Given this list of marker genes E030030I06Rik, Zwint, Pitpnm3, Tial1, Postn, Dmtf1l, Ep300, Smim13, Setdb1, Tsc22d2, Amn1, Fmnl2, Cnot6l, Haus6, Zfp36l2, Arid4a, Ppp2ca, Fbxl12, Cp, Eif2b1, G3bp2, Pan3, Cpsf6, Cav2, Nkd2, Plcl2, Slc23a2, Smim10l1, Vtcn1, Mbtd1, Exd2, Ifi47, Nr4a2, Scai, Rab7, Pfn2, Dnal1, Kcnj13 (potassium inwardly-rectifying channel, subfamily J, member 13), Zfhx3, Sema3b, Gm867, Ccdc85a, Osbpl8, Tyw5 (tRNA-yW synthesizing protein 5), Ppp3r1, Phf21a, Gm4841, Tmprss11e, Sos2, Or13c7c, Rnf103, Tspan15, Phyh, Ptbp2, Fam78b, Pex13, Fgfr2, Runx1t1, Ccdc71l, Alx1, E2f5, Bloc1s2, Bicd2, Tmtc2, Cd160, Mbd3l2, Nab2, Gatad1, Tnfsfm13, Gucd1, Mkrn3, 4930596D02Rik, Themis, Scgb3a1, Dio2, Zfp706, Zfp981, Fnta, Tchh, Tdrd7, 1700029F12Rik, Prlr, Tenm4, Angpt2, Tnfsf13 (NCBI Gene Id 69583), Rspo2, Esp36, Dclk1, Plp1, Dmwd, Syt12, Siah1b, Nr1d2, Pyurf, Msl2, Setx, Slc22a23, Exo1, here is a description of the gene set: Mouse Gene Set: MIR_544_5P studied in species Mus musculus from publication Chen Y, Wang X (PMID 31504780) Genes predicted to be targets of miRBase v22 microRNA mmu_miR_544_5p in miRDB v6.0 with MirTarget v4 prediction scores > 80 (high confidence targets).